The following is a description of a gene set: part of: Downstream signaling of activated FGFR3 studied in species Mus musculus electronically inferred by orthology from the curated human pathway Reactome Pathway: FRS-mediated FGFR3 signaling This event has been computationally inferred from an event that has been demonstrated in another species.<p>The inference is based on the homology mapping from PANTHER. Briefly, reactions for which all involved PhysicalEntities (in input, output and catalyst) have a mapped orthologue/paralogue (for complexes at least 75% of components must have a mapping) are inferred to the other species., and this is the list of marker genes: Grb2, Fgf8, Hras (Harvey rat sarcoma virus oncogene), Fgf23, Fgf1, Fgf4, Fgf5, Fgf20, Fgf17, Frs2, Fgf16, Fgf2